The following is a description of a gene set: The process whose specific outcome is the progression of the diencephalon over time, from its formation to the mature structure. The diencephalon is the paired caudal parts of the prosencephalon from which the thalamus, hypothalamus, epithalamus and subthalamus are derived; these regions regulate autonomic, visceral and endocrine function, and process information directed to the cerebral cortex. species: Homo sapiens Human Gene Set: GOBP_DIENCEPHALON_DEVELOPMENT, and this is the list of marker genes: GSX1, PTCHD1, BMP2, GHRH, SRD5A2, NR4A2, PITX2 (paired like homeodomain 2), ARX, GLI1, CHRNB2, CRH, NRP1, NOG, ALDH1A2, UQCRQ, CDH1, FOXB1, ZEB2, PITX1, CREB1, PAX6, NCOA1, HES1, POU1F1, LHX3, PRDM13, RAX, WNT1, PLXNA3, NKX2-1, PROP1, FGF2, WNT4, HESX1, POU4F1, PLXNA1, KCNC1, TAL2, NDNF, KIAA0319, BAX, OTX1, SIX3, WNT5A, NR0B1, GATA2 (NCBI Gene Id 84724), SEMA3E, OLIG2, KCNC2, BMPR1A, FGF8, GLI2, HMGA2, UBB, BMP4, MSX1 (NCBI Gene Id 4487), OGDH, CNTNAP2 (NCBI Gene Id 26047), SOX3, NRP2, BLOC1S6, TBX19, CTNNB1 (catenin beta 1), GHRHR, POU3F2, RAB3GAP1, SHH, OTP, SRD5A1, SEMA5A, SOX2, HAP1, DRD2, INHBB, SLC6A3, NHLH2, NKX2-6, SALL1, FGF10, GBX2, SMO, RBPJ, ISL1 (NCBI Gene Id 3670)